Given this list of marker genes ADGRB3, NSF, ZNF423, EAF2, KCTD15, GDPD4 (NCBI Gene Id 220032), BNC2, LRTM1, PHOX2B, FEZF2, KLHL1 (kelch like family member 1), SPTB, RAB3C, RARB (retinoic acid receptor beta), TSSK3, CHD2, GPM6A, PHF6, RHOD, ASPA, ALDH1A2, PPOX, BAZ1A, MAGED2, GLRA1, LOX, OR10A5, MAP2, VAX1, COL13A1, HOXB6, HOXB8, DRG1, PDZRN4, CADM1, NRAS (NCBI Gene Id 4893), IL21, HDAC9, MOS, KRT23, CXCL2, MYADML, BCL11B, C6orf136, FBXO11, GNGT1, KRT28 (keratin 28), LINC00052, HOXA3, IQCB1, MYBPC1, PPM1L, PRKAG1, KRT76, SOX4, LRRTM3, TWIST1, NRP1, EPHA7, CHMP2A, TDRD5, TMEM179, VGF, FOXP2, CCIN, FGFR4, HIVEP1, HOXA11, DLGAP4, STAC2, SIAH3, LMO3, KCNK10, CUX1, SALL3, PRRX1, TOB1, DPH2, HOXD10, LUC7L3, TEAD1, NANOS1, PTHLH, ITPR3, SYNGR1, GADL1, TAPBP, NOVA1, C12orf42, SYNPR, FRMD5, RIT1, SUPT16H, CDH10, CLRN1, WNT5A (Wnt family member 5A), GNB3, TREML2, CSNK1G3, PURA, UNC80, NSD1, here is a description of the gene set: Human Gene Set: POU3F2_01 Genes having at least one occurrence of the motif ATGMATWWATTCAT in the regions spanning 4 kb centered on their transcription starting sites. This matches the POU3F2 transcription factor binding site V$POU3F2_01 (v7.4 TRANSFAC). species: Homo sapiens